Given this list of marker genes ARSK, UGCG, GLB1L2, SMPD3, ARSA, NEU4, ARSH, ARSD, ARSL, STS, GBA3, GBA1, B4GALT5, NEU1, ST6GALNAC6, ENPP7, ARSB, ST6GALNAC5, ST8SIA5, ASAH2, GM2A, SMPD1, SUMF2, HEXB, B4GALNT1, CERK, B3GNT5, GLB1L, GLA (galactosidase alpha), A4GALT, NEU3, GALC, FUT1, ST3GAL3, NEU2, GAL3ST1, ST3GAL2, ARSI, HEXA, UGT8, SMPD4, ARSJ, B3GALNT1 (beta-1,3-N-acetylgalactosaminyltransferase 1 (Globoside blood group)), PSAP, B4GALT6, SUMF1, B3GALT4, CTSA, M6PR, GLB1, ARSF, ST3GAL5, GLB1L3, FUT2, SMPD2, ARSG, GBA2, ASAH1, here is a description of the gene set: Glycosphingolipid metabolism Human Gene Set: REACTOME_GLYCOSPHINGOLIPID_METABOLISM species: Homo sapiens